The following is a description of a gene set: Any process that modulates the rate, frequency, or extent of protein tyrosine kinase activity. Human Gene Set: GOBP_REGULATION_OF_PROTEIN_TYROSINE_KINASE_ACTIVITY studied in species Homo sapiens, and this is the list of marker genes: SOCS5, UNC119, SOCS4, LILRA5, ERRFI1, DOK7, SRCIN1, RAP2B, SNX6, ABI1, ADAM17, PTPN1, ZFYVE28, CSF1R, VPS25, CHMP6, PTK6, MVP, ZGPAT, TSG101, RAP2C, CASS4, NEDD9, GPRC5B, GPRC5A